The following is a description of a gene set: Regulation of lipid metabolism by PPARalpha studied in species Homo sapiens Human Gene Set: REACTOME_REGULATION_OF_LIPID_METABOLISM_BY_PPARALPHA, and this is the list of marker genes: NFYB, CD36, MTF1, NCOR1 (NCBI Gene Id 9611), PPARG, SREBF2, NR1H2, ANGPTL4, SIN3B, APOA5, MED17, CPT2, MED29, FAM120B, MED22, MED9, SREBF1, ESRRA, RXRB, BMAL1, PEX11A, FHL2, TXNRD1, HMGCS2, SLC27A1, FADS1, APOA2, THRAP3, CPT1A, RXRA, NRF1, MED7, NFYA, MED11, SULT2A1, RGL1, ACOX1, MED16, NR1H3, ACSL1, MED15, MED12, MED13L, UGT1A9, ME1, NR1D1, ACADM, HMGCS1, AGT, MED31 (mediator complex subunit 31), G0S2, CYP1A1 (NCBI Gene Id 1543), MED30, GLIPR1, PPARGC1A, CHD9, MED10, AHR (aryl hydrocarbon receptor), CLOCK (NCBI Gene Id 9575), TRIB3, CDK8, EP300, NR1H4, NCOA6, FDFT1, ABCB4, PLIN2, MED27, SP1, MED24, MED18, FABP1 (NCBI Gene Id 2168), CARM1, TBL1XR1, APOA1, HMGCR, MED20, ARNT2, MED25, TGS1, TIAM2, ALAS1, NFYC, HELZ2, MED13, RORA (NCBI Gene Id 6095), MED21, HDAC3, TBL1X, PPARGC1B, MED1, NCOA3, ABCA1, NCOA1, MED4, GRHL1, MED23, CREBBP, SIN3A, MED8, CDK19, ARNT, GPS2, CCNC, SMARCD3, MED19, NCOA2, NPAS2, PPARA, MED14, MED26, MED6, MED28, CYP4A11, TNFRSF21, ANKRD1, NCOR2, CYP7A1